The following is a description of a gene set: Neighborhood of MLANA studied in species Homo sapiens Human Gene Set: CAR_MLANA Neighborhood of MLANA melan-A in the CAR expression compendium, and this is the list of marker genes: SULT4A1, SLC12A4, PSG1, PAX6, MC2R, CD40 (NCBI Gene Id 958), SEMA4D, ATP1B2, NPPA, KRT86, SIRPB1 (NCBI Gene Id 93149), ACKR2, ZNF157, RREB1, VAMP1, TNP1, POU4F1, PRSS16, ADCYAP1, TRIM58, SLC4A8, BUD23, ST3GAL2, KRT2, PFKFB2, FOSL1, IGHMBP2, EFNA3, PCBP3, PRPH, CEACAM4, STATH (statherin), MLANA, TNFRSF25, KRT33A, CYP11A1, ZKSCAN3, SLC30A3, WNT10B, IGSF9B (immunoglobulin superfamily member 9B), PVT1, NCKIPSD, POU6F2